Given this list of marker genes Gm21992, Dph2, Mrgprx2, Vdr, Plag1, Snx1, Zc3h7a, Cdyl2, Zfp629, Cab39, Zfp12, Fam163a (family with sequence similarity 163, member A), Zfp710, Adra1b, Smco4, Scgb2b26, Foxk1, Kmt2e, Gng4, Clic5, Zfand3, Majin, Cdc14b, Tmem135, Gpr132, Dmbx1, Arhgap39, D6Wsu163e, Hexim1, Klhl2, Cpeb4 (NCBI Gene Id 67579), Arhgef9, Ogt, Pacsin1, Ikbkb, Lonrf1, Zfp580, Nav1, Gxylt2, Desi1 (desumoylating isopeptidase 1), Dpy19l3, Abca4, Zfp609, Tspyl1, Kif3a, Zc3h7b, Sertm1, B3galt6, Bicd2, Hey2, Fbxl16, Btla, Pip4p1, Traf1, Mrps17, Ctdspl, Sarm1, Nr5a1, Gpr165, Ube2e3, Plagl1, Eif4b, Pim2, Cgnl1, Erlec1, Plxnb2, Ttpal, St6gal1, Dynlrb2, Cadm3, Rbm4, Klri2, Il36rn, Aqp7, Camta1, Plxna2, Zfp704, Kpna6, Pirt, Foxp3, Dock5, 4921536K21Rik, Nid1, Emc1, 6430571L13Rik, Trpc4, Ctcf, Ksr2 (NCBI Gene Id 333050), Frs2, Mosmo (modulator of smoothened), Cfap61, Catspere2, Nrcam, Dpysl2, Mtpn, Hgf, Tnfsf8, Ube2n, Arhgap19, Bace1, Agxt2, Sv2b, Adgrl1, Prr14l, Srsf2, Nt5dc3, Elk1 (NCBI Gene Id 13712), Fbxl18, Tbcel, here is a description of the gene set: studied in species Mus musculus Genes predicted to be targets of miRBase v22 microRNA mmu_miR_7050_5p in miRDB v6.0 with MirTarget v4 prediction scores > 80 (high confidence targets). Mouse Gene Set: MIR_7050_5P from publication Chen Y, Wang X (PMID 31504780)